Given this list of marker genes S100a9, Tmeff2 (NCBI Gene Id 77664), Tgfb2, Ar, Nox1, here is a description of the gene set: Mouse Gene Set: GOBP_REGULATION_OF_INTEGRIN_BIOSYNTHETIC_PROCESS Any process that modulates the frequency, rate or extent of the chemical reactions and pathways resulting in the formation of integrins. species: Mus musculus